Given this list of marker genes CHFR, MAPK15, CDC20, MOS, ZWINT, KNL1, TTK, here is a description of the gene set: The cell cycle process in which a cell progresses from metaphase to anaphase as part of meiosis. Human Gene Set: GOBP_METAPHASE_ANAPHASE_TRANSITION_OF_MEIOTIC_CELL_CYCLE species: Homo sapiens